The following is a description of a gene set: The process in which a relatively unspecialized mesodermal cell acquires the specialized structural and/or functional features of a cardioblast. A cardioblast is a cardiac precursor cell. It is a cell that has been committed to a cardiac fate, but will undergo more cell division rather than terminally differentiating. Mouse Gene Set: GOBP_CARDIOBLAST_DIFFERENTIATION species: Mus musculus, and this is the list of marker genes: Rest, Prickle1, Nrg1, Nkx2-5, Eef1ece2, Tgfb2, T, Eomes, Tbx2, Notch1, Dhx36, Itgb1, Myocd, Grem1, Srf, Isl1, Tbx5, Rbpj